Given this list of marker genes Cib1, Spdya, Rnf17, Fancc, Tssk1, Mfn2, Dcaf13, Gm4297, Asz1, Gm10230, Kdm1b, Fer (NCBI Gene Id 80679), C2cd6, H1f7, Catsperb, Gm21996, Spaca3, Garin5a, Cfap52, Tmem95, Gm1993, Mei1, Cylc2, Fbxo5, Angpt2, Dmrtc2, Foxo3, Sbf1, Gm2012, Pygo1, Dnmt3l, Xlr3b, Ctcf (NCBI Gene Id 270092), Map7, Kat5, Hook1, Ihh, 4930447C04Rik, Piwil1, Stra8, Zscan21, Aurka, Armc12, Plcb1, Ccdc159, Zfp37 (zinc finger protein 37), Wt1, Kash5, Gm28961, Dnali1, Pebp1, Fbxw11, Nanos3, Defb1, Gm5168, Rsph6a, Slxl1, Fndc3a, Gm28102, Gm29276 (predicted gene 29276), Meioc, Catsper3, Stau1, Spesp1 (sperm equatorial segment protein 1), Edn1, Gsk3a (NCBI Gene Id 76828), Diaph2, Six5, Gdf9, Gm28870 (predicted gene 28870), Tdrd1, Tbpl1, Mlh1, Tdrkh, Prmt7, Ropn1, Llcfc1, Ccdc42, Zp3, Bnc1, Ddias, Kcnq1ot1, Wee2, Sun5, Trip13, Lyzl6, Zdbf2, Gk2, Sufu, Cfap54, Cabcoco1, Ccdc62, Garin1b, Taf7l (NCBI Gene Id 74469), Nup210l, Ddx20, Paqr8, Misfa, Celf1, Rhbdd1, Gm1140, Acvr1, Bbs2, Pmfbp1, Bsph2, Cfap53, Btbd35f1, Lin28a, Cfap57, Paqr5, Prss42, Sycp1, Ube2b, Lrrc46, Calca, Prdm14, Nodal, Kmt2b, Ddx25, Chd5, Pde3a, Ezhip, Cfap97d1, Psme4, Tpgs1, Gm20824, Catspere1, Adad2, Ehmt2, Garin5b, 1700013H16Rik, Ptch1, Nsun2, Spem3 (SPEM family member 3), Kmt2d, Tssk6, Sirt2, Meiosin, Ccr6, Ccdc63, Npm2 (NCBI Gene Id 328440), Ccdc38, Xlr5b, Dcaf17, Fancg, Fsip2, Spink2, Garin2 (NCBI Gene Id 74719), Qki, Gm28919, Sox3, Zar1, Bcl2l1, Gm2030, Cyp51, H2al2a, Nppc (NCBI Gene Id 18159), Semg1, Defb37, Sohlh2, Rnf8, Bcas2, Chn2, Slc9a8, Kat8, Mettl3, Dmc1, Xlr (X-linked lymphocyte-regulated), Cxcr4, Src, Zfp57, Lyzl4, Cfap47, Tm9sf5 (NCBI Gene Id 245423), Dld, Zfp42, Arid4a, Dnmt3b (NCBI Gene Id 13436), Eif4g3, Gm5934, Cfap61, Tut4, Jam3, Sycp3, Ybx2, Prss43, Ythdc2, Tssk2, Fmn2, Efcab9, Zfx, Folr2, Nme5, Tnfaip6, Cfap221, Drc7, Rbm46, Tsga8, Folr1, Majin, Ttc12, Mns1, Taf4b, Armc3, Tial1, Smad5, Pcsk4, Klc3, Gm773, Spink1, Sly, Cdc25b, Inhbb, Gli1, Catsper4, Gm20843, Gnas, Cfap65, Septin14, Akt1, Izumo1, Adad1, Rara, Meg3, Cd9, Hyal5, Osbp2, Sox30 (NCBI Gene Id 278440), Spef2, Septin4 (septin 4), H3f3a, Aspm, Ythdf2, Rnase9, Cep128, Tcp11x2, Gm29554, Adam1a, Svs3b, Dnd1, Mei4, Tbc1d21, AU040320, Pithd1, Ccnb1, Gm20736, Spinkl, Alms1, Ift81, Cdyl, Rfx2, Gm21627, Bmp4, Gopc, Sebox, Ttll1, Arid4b, Pde5a, Zmynd15, Dazl, Ccdc136, Rsph1, Gm21858, Ift88, Mos, Vps54, Tcp11, Xlr4b, Smchd1, H19, Tut7, Bscl2, Hmgb2, Gm20820, Grb14, Catsperd, Mast2, Hormad1, Tmprss12, Gm28510 (NCBI Gene Id 102638101), Nphp1, Cep57, Piwil2, Pafah1b1, Pdilt, Catsper1, Brca2, Insl3 (NCBI Gene Id 19774), Cfap206, Mdk, Rec114, Zbtb16, Spaca6, Ttc21a, Mtor, Nobox, Dzip1, Shb, Yif1b, Tmem119, Fam209, Ctnnb1, Rps6ka2 (ribosomal protein S6 kinase, polypeptide 2), Vps13b, Garin1a, Chtf18, Pfn4, Paqr7, Npr2, Msh2, H1f9, Gm10488, Spaca1, Zar1l, Ythdc1, Ropn1l, Sec23ip, Mamld1, Lsm14b, Iho1, Spag6, Stk11, Marf1, Tdrd5 (tudor domain containing 5), Zfp830, Drc1, Dhh, Ptk2b, Mcmdc2, Eqtn, Pank2, Lgr5, Bmp8b, Aff4, Xlr5a, Armc2, Gm6121, Cdkn1c, Rxfp2, Prdm1, Slc26a6, Ccdc146, Rps6kb1, Spag16 (NCBI Gene Id 98632), Adgb, Stau2, Trim28, Cfap58, Gm20817, Prkg1, Catspere2, Stk33, Zglp1, Klhl10, Tpst2, Dcst1, Ercc1 (NCBI Gene Id 13870), Gm21294, Amh, Nectin2, Gsk3b (glycogen synthase kinase 3 beta), Catsperz, Bmp8a, Agfg1, Galntl5, Cxcl12, Abhd2, Spam1, Frey1, Cfap44, Insl6, Actl7a (actin-like 7a), Spata16, Pabpc1l, Oog1, Sfrp1, Mfsd14a, Pygo2, Fsip1, Bax, Sohlh1, Rps6, Cabyr, Zpbp, Gmcl1, Tdrd12 (tudor domain containing 12), Tarbp2, Poc1b, Xlr5c, 4930451I11Rik, Iqcg, Garin4, Ppp2r1a, Pln, Iqcf1, Ing2, Terb2, Adrm1, Akap4, Runx1, Tnp1, Slc26a3, Gm20911, Cntrl, Rnf2, Mycn, Slx, Dcst2, Gm21760, Pld6, Spo11 (NCBI Gene Id 98973), Pdcl2, H3f3b, Ptn, Gm20890, Dpy19l2, Adam7, Spata46, Glipr1l1, Tnk2, Hfm1, Atm, Tbata, H2bc1, Sppl2c, Strbp (NCBI Gene Id 99105), Zpbp2, Airn, Fshr, Etv5, Gnasas1, Bcl2, Cfap157, Catsper2, Spem1, Bsph1, Agfg2, Brip1, Ccnb1ip1, Igf1, Cfap43, Brdt, Nanos1, Svs3a, Cftr, Dnmt3a, Ttll5, Tssk3, Slirp, Fscn3, Vdac3, Oosp2, Pik3ca, Gm20870, Spag17, Retn, Tssk4, Xlr4c (NCBI Gene Id 72891), Hexb, Eed, Xlr4a (NCBI Gene Id 630479), Prss44, Tdrd7, Hspa2, Selenof, Ereg, Meig1, Gm7958, Ddx4, Gm5169, Dnah1, Zfy2, Neurl1a, Kitl, Bbs4, Tsix, Pla2g3, Jam2, Gm5935, Prm2, Slc22a14, Ndn, Inhba, Tdrd6, Cfap119, Gm21865, Xlr3a, Cep131, Ica1l, Acrbp, Gpr149, Gm14525, Ptx3, Spaca5, Cfap69, Dmrt1, Rab1a, Tmf1, Washc1, 3830403N18Rik, Kit, Ednra, Figla, Adcy10, Ctcfl, Tnp2, Tbc1d20, Wdr54, Izumo3, Spag6l, Garin3, Prkaca, Cylc1, Wnt4, Ift56, Fxr1, Mkks, Rimbp3, Iqcn, Izumo1r, Gm21095, Nanos2, Fzd4, Axdnd1, Washc5, Xlr3c, Dnhd1, Pacrg, Zmynd12, Kdm3a, Bmpr1b, Actl9, Gm28576, Itga3, Oca2, Wdr77, Mecp2, Mta2, Epc1, Prm1 (protamine 1), Cfap70, Tuba8, Xist, Ube2j1, Rec8 (REC8 meiotic recombination protein), Gm29866, Gm21117, Bbof1, here is a description of the gene set: A process, occurring at the cellular level, that is involved in the reproductive function of a multicellular organism. Mouse Gene Set: GOBP_CELLULAR_PROCESS_INVOLVED_IN_REPRODUCTION_IN_MULTICELLULAR_ORGANISM species: Mus musculus